The following is a description of a gene set: Genes containing one or more binding sites for (TCOF1) in their promoter regions (TSS -1000,+100 bp) as identified by GTRD version 20.06 ChIP-seq harmonization. from publication Yevshin I, Sharipov R, Kolmykov S, Kondrakhin Y, Kolpakov F (PMID 30445619) species: Homo sapiens Human Gene Set: TCOF1_TARGET_GENES, and this is the list of marker genes: RAD52, PRCC, CIAO3, SNORA72, NOC4L, HDGF, SEZ6L, CDCA3, GSPT1, C1orf159, CCDC90B, CCDC90B-AS1, DDX51, BOD1, RAPGEF1